The following is a description of a gene set: studied in species Homo sapiens Genes predicted to be targets of miRBase v22 microRNA hsa-miR-8087 in miRDB v6.0 with MirTarget v4 prediction scores > 80 (high confidence targets). Human Gene Set: MIR8087 from publication Chen Y, Wang X (PMID 31504780), and this is the list of marker genes: TIMD4, FNIP2, PAN3, HEPACAM2, SOX5, GUCY1A1, SEPHS1 (NCBI Gene Id 88214), NOVA1, IFNK, EDEM3 (NCBI Gene Id 87240), RCN2, AHCTF1, FMR1, TMEM263, TMX3, CSRNP3, ESRP2, SIN3A, SRSF4, HNRNPC, TDP1, REEP1 (NCBI Gene Id 65055), C17orf75, ARHGAP32, UBE2V1, ARGLU1, CACNB2, EAF1, STRN3, UBE2E1, DGCR8, SINHCAF, CHL1, MGST1, NSL1, GLI2, ADCY2, ZEB1, KDM7A, ZUP1, PEDS1-UBE2V1, NR3C1, RORA, PI4K2B, SOX6, ATF2, LIPA, PRMT9, AP1G1, NAPG, DEPDC1B, SH3KBP1, HSPA4L, PGAP1, AHR, MAP3K15, WDCP, RIC1, SP3, SKP1, DCUN1D1, PTAR1, OSBPL1A, PDE4D, FAM168A, ZNF281, RIMS1, EDAR, VAPA, ANKFY1, NCKAP5, RIPOR3, SPRED1, LYSMD2, AZIN1, USP33, CRYZL1, MPPED2, MAPK6, MYEF2, SAYSD1, VAV3, CD200R1, NOL4L, E2F3, LMCD1, TRAPPC10 (NCBI Gene Id 7109), SLC30A4, EML4, ADAM9, GLTP, RSBN1, GAB3, KDM6A, BNIP2, IL23A (interleukin 23 subunit alpha), MRAS, JADE1, GDAP1, TDRKH, SHCBP1, POLR3F, SYBU, MEIS3, CUL3, IMPG2, ABHD13, FYN, HIBCH, ZNF136, VCPIP1, RBPJ, ARHGAP12, HLCS, IL2RB, GRIA2, KIAA0825, IKZF2, RAB5C, LIN28B, MAOB, QRSL1, CXCL6, INSIG1, ST8SIA4, SPTSSB, TMC5 (NCBI Gene Id 79838), CDC37L1, TM9SF3, C4orf19, EPHA5, YIPF6, TSPAN3, RSF1, ZNF280C, SNX9 (NCBI Gene Id 51429), ANKRD49, TLX3, UQCC6, ZDHHC9, EPM2AIP1